The following is a description of a gene set: Immune cell-specific expression is one indication of the importance of a gene's role in the immune response. In order to identify such patterns, we set out to broadly profile gene expression in a variety of immune cells. studied in species Homo sapiens Human Gene Set: GSE22886_IGG_IGA_MEMORY_BCELL_VS_BM_PLASMA_CELL_DN Genes down-regulated in comparison of memory IgG IgA B cells versus plasma cells from bone marrow and blood. from publication Abbas AR, Baldwin D, Ma Y, Ouyang W, Gurney A, Martin F, Fong S, van Lookeren Campagne M, Godowski P, Williams PM, Chan AC, Clark HF (PMID 15789058), and this is the list of marker genes: TIMP1, SDC1, DEXI, EPS8L2, KCNG2, WDR45, GLT8D1, TONSL, CLCC1, DNAJB9, RRBP1, PYCR1, CLIC3, WIPI1, BNIP3, FICD, NDUFA4L2, GAS6, ACBD4, MUC5B, CD14, SEMA3B, KLF6, APOBEC3F, FAM149A, MAPK12, ADA2, COPG1, SAR1A, APOC3, FUZ, LEPROTL1, CST3, PRODHLP, CRABP2, FIS1, RBM47, LMNA, RRP12 (NCBI Gene Id 95039), TSPAN4, PYCR3, CFD, FZD2, FBXW7, SRPRB, LGALS3, TP73, INSR, TMEM208, MVD (NCBI Gene Id 4597), VKORC1, SDF4, TOP6BL, VENTX, CELA2B, MXD4, FNDC3B, BACH1, TBL2, RGCC, CAV1, RUNDC3A, EHD4, FSCN2, BLVRA, C1GALT1C1, RALY, PDK1, QPRT, MBNL2, GZMM, ABHD14A, QPCT, SOCS3, PDE4A, MDK, NUCB2, R3HCC1, TFG, MACROD1, PDXK, EXT1, TCTN1, IGLL1, ANAPC13, FER1L4, DNASE2, IGF1, CHPF (NCBI Gene Id 79586), IGKV1D-13, TM7SF2, HOXA6, KCNJ4, TTC38, AMH, HMCES, CTSW, SCAMP5, DNAJC3, MYL6B, WNT4, SEC24A, NEU1, CADM1, GNRH2, NTN1, MMP17, DPM2, BMS1P20, PAK5, GP1BB (glycoprotein Ib platelet subunit beta), IFT20, AGA (NCBI Gene Id 175), STN1, LCN1, PRCP, ST6GALNAC4, PELI1, LRRC41, KDELR1, RCBTB2 (RCC1 and BTB domain containing protein 2), RAB1A, SPAG4, SLC1A4, IGKV3-20, POMC, RHEB, NENF, KCNN3, SEMA4A (NCBI Gene Id 64218), NUS1P3, LRPAP1, RRP1, DKKL1 (dickkopf like acrosomal protein 1), IFNAR2, YIPF2, FGF6, AIF1, IGLV4-60, PRDM12, KDELR3 (KDEL endoplasmic reticulum protein retention receptor 3), ARHGEF16, ARFGAP3, RAPGEF2, TMCO1, MPST, SMPDL3B, BSCL2 (BSCL2 lipid droplet biogenesis associated, seipin), MORF4L2, PCYT1B, CFLAR, DNAJC1, RAB13, MAGEF1, FUCA1, DUSP5, CLN3, ZNF688, RRAD, PAM, HYI, PSAP, BST2, KLHDC2, GPRC5D, HSPA13, SLC3A2, TAPBPL, CDKN1C, HSD17B8, NFKBIA, OBSCN, LIME1 (NCBI Gene Id 54923), MCFD2, TRIB1, TM9SF1, GBX2 (NCBI Gene Id 2637), MOK, BTG3, ADIPOR1 (adiponectin receptor 1), ATOX1, PREB, ARL1, LAMB2, CD300A, CREB3L2, PODXL2, PMM2, NAA10 (NCBI Gene Id 8260), MCF2L-AS1, LAPTM4A, ITFG1, GRWD1, DNPH1, ITM2C, RUNX1, EDEM2